Given this list of marker genes Kdelr2, Mprip, Rit2, Grk2, Sorl1, E230001N04Rik (NCBI Gene Id 320187), Kdelr3, Sun2, Supt7l, Hdac3, Txn1, Taf3, Hk1, Nr5a1, Adcy6, Akt1, Tspo, Morc3, Cdk5, Dbn1, Bard1, Cav1, Gja1, Os9, Arl2, Golph3, Syne1, Rer1, Tnrc6a, Sun1, Hnrnpu, Mdfi, Arl2bp, Taf8, Pkp2 (plakophilin 2), Grik5, Frey1, Tmed2, Hk2 (hexokinase 2), Skp1, Fam76b, Hspa5, Fkrp, Bbs4, Vps13d, Vps13c, Ank3, Srgn, Pgr, Insig2, Ccdc88a, Kdelr1, Park7, Topors, Sppl2c, Insig1, Cd4, Sp100, Ankrd13c, Sufu, Pml (NCBI Gene Id 338524), Vps13a, Ciz1, Rangap1, Pink1, here is a description of the gene set: Mouse Gene Set: GOBP_MAINTENANCE_OF_PROTEIN_LOCATION_IN_CELL Any process in which a protein is maintained in a specific location within, or in the membrane of, a cell, and is prevented from moving elsewhere. studied in species Mus musculus